Given this list of marker genes Stag1, Smc3, Rad21, here is a description of the gene set: electronically inferred by orthology from the curated human pathway This event has been computationally inferred from an event that has been demonstrated in another species.<p>The inference is based on the homology mapping from PANTHER. Briefly, reactions for which all involved PhysicalEntities (in input, output and catalyst) have a mapped orthologue/paralogue (for complexes at least 75% of components must have a mapping) are inferred to the other species. Reactome Pathway: Cohesin Loading onto Chromatin species: Mus musculus part of: Mitotic Telophase/Cytokinesis